The following is a description of a gene set: Catalysis of the reaction: S-adenosyl-L-methionine + histone H3 L-lysine (position 56) = S-adenosyl-L-homocysteine + histone H3 N6-methyl-L-lysine (position 56). This reaction is the addition of a methyl group to the lysine residue at position 56 of the histone H3 protein. studied in species Mus musculus Mouse Gene Set: GOMF_HISTONE_H3K56_METHYLTRANSFERASE_ACTIVITY, and this is the list of marker genes: Prmt8, Ndufaf7, Prmt6, Prmt2 (NCBI Gene Id 50502), Prmt9, Ehmt2, Carm1, Prmt5, Prmt1